Given this list of marker genes TMEM120A, TIPIN, MCTS1, ESCO2, TASP1, MTMR10, CEMIP, NANS, MAPK7, RNF7, MAVS, ABCB7, LOX, STARD9, ACOT4, LTO1, POGLUT2, EED (embryonic ectoderm development), AKAP8L, NBR1, C8orf76, NHERF2, ASPM, AURKA, TPRKB, PRR14L, ZNF619, SLC22A3, MAP1S, PIWIL2, GCSH, WDR45, RANBP10, KCTD15, TFIP11, OPN3, DNAJC12, YBX3, SPTLC3, C1orf174, PKD1, TIMM9, HBP1, IPO7, KDM8, RAD1, DNA2, GPR155, PRUNE1, NFYA, MTHFD1L, GAB1, VCPKMT, AP2A1, ZNF330, FOXD4L1, TIAM2, TTC33, LONRF1, NOB1, RANBP9, ZNF408, SPRYD3, CREBZF, DDX11, PHKG2, GPAM, CNST, LSM14B, TGFBRAP1, CDK8, SF3A1, ACOT11, AMMECR1L, ASB7, GAS2L1, OXLD1 (NCBI Gene Id 339229), CBX5, ING1 (NCBI Gene Id 3621), PTGIR, ALG14, ETFRF1, ZNF799, TEAD1, SARS1, SLC37A4, CTNNBL1, RAD17, PEX10, GBA2, EID1, NAGPA, FOXD2, DTYMK, C6orf118, AKT1S1, NHLRC1, WDR3, TRIM24, PDIK1L, ZC3H12D, METTL5, TM6SF1, ALDH4A1, ACO1, DHRS13, TNFAIP1, ABCC9, HMCES, SGSH, KLF10, MED11, GGNBP2, REG3G, ZDHHC9, FHL2, TLCD1, HROB, CNIH1 (cornichon family member 1), CAPN2, CCNA2, SIN3A, OGFOD1, TNNC1, ILKAP, CUL4A (NCBI Gene Id 8451), IPO5, TRIM47, MTR, NR2C2AP, ZZZ3, ELF2, ABCD3, SLC5A12, CBR3, RCAN3, SMIM11, MEGF9, SH3BP5, SIGMAR1, STRADB, TSC22D4, TRIM9, TRIM59, TMEM131L, CD79B, GULP1, NKRF, POU2F1, GART, WEE1, MIDEAS, EIF4EBP1, UVSSA, GPR68, MOGS, SEC11A, NCBP2, FAM98C, ULK2, UBR5, NDUFAF4, BRD8, KLC1, PAF1, NODAL, CAST, TRIB2, KIF22, ZXDC, FZD4, ZSCAN12, INSR, HAS1, FCER1A, DUSP19, MOAP1, MYBPC1, SBNO1 (NCBI Gene Id 55241), APOC4, MKS1, HOXA9, SSNA1, CCN5, RINL, TIMP2, BORA, NTPCR, CENPL, CASC3, FAM50A, MRPL49, LRP6, AKAP1, SLC36A2, TEX10, WFS1, MED8, ENSG00000267882, here is a description of the gene set: Bone marrow-derived dendritic cells were left untreated or stimulated with lipid-transfected double-stranded DNA or CpG oligonucleotides for four hours before harvesting. from publication Stetson DB, Medzhitov R (PMID 16413926) Genes down-regulated in comparison of dendritic cells (DC) treated with immunosuppressive DNA versus the untreated cells. Human Gene Set: GSE2197_IMMUNOSUPPRESSIVE_DNA_VS_UNTREATEDIN_DC_DN studied in species Homo sapiens